Given this list of marker genes D630023O14Rik, Ildr2, Gm22357, Gm18186, 1700029M03Rik, Tiprl, Snord47, Rcsd1, Rabgap1l, Gm18900 (NCBI Gene Id 100417923), Gm22671, Prrx1, Prrc2c (proline-rich coiled-coil 2C), Mael, Gm32391, Gm5049, Rpsa-ps1, Fmo3, Gm24940, Gm7626, Gm23528, Gm26224, 9430087J23Rik, Xcl1, Firrm, 4933417C20Rik (NCBI Gene Id 98212), Sft2d2 (NCBI Gene Id 98387), Gm15853 (NCBI Gene Id 100503318), Fasl, Tada1, Fmo6, Gpr52, Zbtb37, Fmo2, Mroh9, Rgs5, Scyl3, Mettl18, 2810442N19Rik, Gm16701, Gm5705, Pigc, Gm5265, 4930568G15Rik, Fmo4, Ankrd45, 6720464F23Rik, Gas5, Dnm3, Gm4846, Cd247, Gm16418, Gm37754, Gm17868, Lmx1a, Gm6286 (NCBI Gene Id 672193), Cenpl, Rc3h1, Aldh9a1, Suco, Lrrc52, Gm23212, Gm33354, Mir6354, Gpa33, Atp1b1, 5330438I03Rik, Nme7, Rxrg, Kifap3, Tmco1, Mir6348, Rgs4, Fam78b, Gm22489, Pbx1, Blzf1, Fmo1, Gm24988, Dars2, Gm25789, F5, Serpinc1, Cacybp, Ccdc181, Dpt, Mettl13, Sele, Dcaf6, Ntmt2, Mpzl1, Slc19a2, Ccdc190, Uck2, Snord78, Mir1927, Myocos, Nuf2, Gm20471, Mir6347, Gm16548, Tbx19, Gm7496, Tnfsf18, Gorab, Gm19057, Gm15429, Mgst3, Gm31925, Styxl2, Gm4847, Vamp4, Gm2453, Gm10176, Mrps14 (mitochondrial ribosomal protein S14), Gm26685 (predicted gene, 26685), Adcy10, Gm37083, Gm34767, Mir199a-2, Gm20743, Klhl20, Gm22434, 4930558K02Rik, Gm24637, Tnfsf4, Gm18407, Creg1, Snord80, Mpc2, Prdx6, Dnm3os, Gm4954, Gm6177, Myoc, Mir214, Gm32999, Pou2f1, Gpr161 (G protein-coupled receptor 161), Selp, Gm2343, Pogk, 1700063I16Rik, Sell, Tex50, Gm17976, Fmo9, Tnn, here is a description of the gene set: studied in species Mus musculus Mouse Gene Set: chr1H2